Given this list of marker genes ADD1, ADD2, CAPG, CAPZA1, MTPN (NCBI Gene Id 94351), CAPZA2, CAPZA3, CAPZB, here is a description of the gene set: A heterodimer consisting of alpha and beta subunits that binds to and caps the barbed ends of actin filaments, thereby regulating the polymerization of actin monomers but not severing actin filaments. Human Gene Set: GOCC_F_ACTIN_CAPPING_PROTEIN_COMPLEX species: Homo sapiens